The following is a description of a gene set: SUMOylation of SUMOylation proteins species: Homo sapiens Human Gene Set: REACTOME_SUMOYLATION_OF_SUMOYLATION_PROTEINS, and this is the list of marker genes: NUP210, SUMO1, NUP88 (NCBI Gene Id 4927), POM121, SEH1L, NUP160, NUP98, UBE2I, NUP62, NUP214, RANBP2, NUP37, AAAS, NUP205, NUP35, RAE1, NUP155, NUP58, NUP85, NUP153, SEC13, NUP93, SUMO2, TOPORS, NUP43, NUP50, NUP54, NUP188, PIAS4, NUP133, NUP107, NDC1, POM121C, TPR, NUP42